The following is a description of a gene set: species: Mus musculus Mouse Gene Set: GOBP_TERMINAL_BUTTON_ORGANIZATION A process that is carried out at the cellular level which results in the assembly, arrangement of constituent parts, or disassembly of a terminal button. A terminal button is the terminal inflated portion of the axon, containing the specialized apparatus necessary to release neurotransmitters., and this is the list of marker genes: Snapin, Chd4, Nlgn2, Nlgn3, Snap91, Vps35, Slitrk3 (NCBI Gene Id 386750), Nlgn1, Picalm